Given this list of marker genes Prpf4b, Sumf1, AU040320 (NCBI Gene Id 100317), Sptbn1, Rap2c, G3bp2, Nploc4, Vwc2l, Glce, Elavl4, Pou3f3, Btf3l4, Eqtn, Glra2, Rc3h1, Slc7a2, Eid1, Tead1, Rc3h2, Ak7, Zc3h12c (NCBI Gene Id 330940), Sgsm2, Mastl, Stx7, Galnt13, Lrch1, Tfdp1, Mxd3, Pals1, Kcnj2, Abl2 (ABL proto-oncogene 2, non-receptor tyrosine kinase), Fkbp1b, Maf, Cited2, Ppp6r3, Rad21, Tppp, Vsnl1, Mier3, Kdm2b, Spg11, Tmx4, Ivd, Rufy2, Btbd2, Fmr1, Pnp, Skida1, Stmn1, Sh3bp5, Isl1, Ptchd1, Jazf1, Apbb2, Ago3, Map3k12, Ddx55, Rnf44, Rora, Jpt1, Elp4, Map3k2, Rbm26, Idua, Zfp14, Pcnx1, Rabgap1, Myt1l, Kctd10, Card10, Kif13a, Hdac8, Rragd, Negr1, Dyrk1a, Arid4b, Vps26a, Npy1r, Selenot, Hif1a, Ranbp17, Map3k11, Zbtb18, Ppp2ca, Rfx6, Cask (NCBI Gene Id 236691), Ikzf2, Esrrg, Nr2c2, here is a description of the gene set: Mouse Gene Set: MIR_1930_3P species: Mus musculus Genes predicted to be targets of miRBase v22 microRNA mmu_miR_1930_3p in miRDB v6.0 with MirTarget v4 prediction scores > 80 (high confidence targets). from publication Chen Y, Wang X (PMID 31504780)